The following is a description of a gene set: Acral blistering Human Gene Set: HP_ACRAL_BLISTERING species: Homo sapiens Bullae (defined as fluid-filled blisters more than 5 mm in diameter with thin walls) of the skin with an acral distribution (affecting peripheral regions such as hands and feet)., and this is the list of marker genes: PLEC, ITGB4, FBXO28, SMARCAD1, KRT5, COL7A1, KRT14, FERMT1, COL17A1